The following is a description of a gene set: studied in species Homo sapiens Human Gene Set: MORF_MYST2 Neighborhood of MYST2 MYST histone acetyltransferase 2 in the MORF expression compendium Neighborhood of MYST2, and this is the list of marker genes: SLC12A4, PRPH, ODF1, NHERF2, PIM1, PDPK1, KAT7, RASSF7, PEX10, PRPF8, EFNA3, SNW1, RAP1GAP2, GPR161, TPMT, ARVCF, CAMK2B, TNK2, ZNF337, PFKFB2, LY6G6C (lymphocyte antigen 6 family member G6C), CNTN1, CNPPD1, TSPO2, LGALS9, GPRIN2, B4GALT3, STK19, XRCC2, GNL1, PNMT, TUB, ALDH4A1, DNAJC8, DRG2, GSK3A (NCBI Gene Id 2931), ZBED1, RXRB, GPR35, GIGYF2, SUN2 (Sad1 and UNC84 domain containing 2), RPS27A (ribosomal protein S27a), FZR1, E2F1, H3-3A, PCBP3, GTF2F1, NR1H2, KIF21B, UBE3B, PTGER3, GRK2, VAMP1, MVK, ZFPL1, ORC1, USP11, HNRNPK, M6PR, RPL22, NUDT3, LPAR2, PRKCSH, CNOT4, MAN2C1, ARAF, APOBEC3C, GRM4